The following is a description of a gene set: Any process that modulates the rate, frequency, or extent of the production of a cytokine that contributes to the immune response. species: Homo sapiens Human Gene Set: GOBP_POSITIVE_REGULATION_OF_MYELOID_LEUKOCYTE_CYTOKINE_PRODUCTION_INVOLVED_IN_IMMUNE_RESPONSE, and this is the list of marker genes: SPON2, CAMK4, SEMA7A, SIRT1, DDX1, LAPTM5, GPRC5B, RIGI, RTN4, PYCARD, MYD88, FCER1G, TLR3, SYK, NR4A3, BCL10, MAPKAPK2, HLA-G, CD36, PANX1, RIPK2, P2RX7, CARD9, DDX21, WNT5A, TLR7, LILRB1, PLCG2, TICAM1, MIF, NOD1, CD74 (NCBI Gene Id 972), DHX36, KIT, TLR4, MAVS